The following is a description of a gene set: The replication of a viral RNA genome. species: Mus musculus Mouse Gene Set: GOBP_VIRAL_RNA_GENOME_REPLICATION, and this is the list of marker genes: Top2b (NCBI Gene Id 319393), Atg16l1, Top2a, Morc2a, Atg16l2, Setdb1, Trim28, Tasor, Zfp809, Atg7, Fmr1, Hmga2, Apobec3, Atg5, Tmem41b, Smarcb1, Pcbp2, Vapb, Fbxl2, Aicda, Inpp5k, Pcbp1, Mphosph8, Morc2b, Phb1, Ddx56